The following is a description of a gene set: studied in species Mus musculus A protein complex that possesses DNA helicase activity. Mouse Gene Set: GOCC_DNA_HELICASE_COMPLEX, and this is the list of marker genes: Rmi2, Helq, Rmi1, Top3a, Blm